The following is a description of a gene set: Any process that activates or increases the frequency, rate, or extent of T cell tolerance induction. studied in species Mus musculus Mouse Gene Set: GOBP_POSITIVE_REGULATION_OF_T_CELL_TOLERANCE_INDUCTION, and this is the list of marker genes: Tgfbr2, Lilrb4b (NCBI Gene Id 14727), Lilrb4a, Foxp3, Itch (NCBI Gene Id 77732), Ido1, Cblb, Nr5a2, H2-M3, Cd3e